Given this list of marker genes SMG9, RDH11, RECQL, CDH11, HS2ST1, NSD2, HIVEP2, here is a description of the gene set: Human Gene Set: HP_ATTACHED_EARLOBE Attachment of the lobe to the side of the face at the lowest point of the lobe without curving upward. Attached earlobe studied in species Homo sapiens